The following is a description of a gene set: species: Mus musculus Any process involved in the maintenance of an internal steady state of calcium ions within an organism or cell. Mouse Gene Set: GOBP_CALCIUM_ION_HOMEOSTASIS, and this is the list of marker genes: Smdt1, Gp1bb, Fam20a, Sgcd, Cxcl11, Prkcb, Hexb, Fkbp1a, Cx3cl1, Hcrtr1, Letm1, Ccl21a, Fam3a, Ptpn6, Ccl19-ps3, Plce1, Sv2b, Trpc4, Trpv4, Synpo, Slc8a2, Slc24a5, Htr2b, Cacna1s, Myo5a, Tmbim6, Mfn2, Dhrs7c, Trpc7, Myh7b, Casr, Bdkrb1, Pdpk1, Hap1, Drd4, Drd3, Stc1, Trpc6, Trpc3, Selenok, Trpv6, Itpr1, Tmem64, Plcd1, Tmem203, Fto, Cav2, Mcub, Tmco1, Trpm2, Slc24a1, Adora1, Slc10a7, Glp1r, Lhcgr, Erc1, Bax, Htr2c, Fgfr1, Anxa7, Cxcr3 (NCBI Gene Id 12766), Atp2c2 (NCBI Gene Id 69047), Calb2, Prkca, Rgn, Ccl19-ps4, Dbi, Sppl2c, Ccl21b, Csrp3, Nt5e, Hoxa3, Atp13a2, Ccl21f, 1600014C10Rik, Gpr39, Slc24a4 (solute carrier family 24 (sodium/potassium/calcium exchanger), member 4), Stim1, Ptk2b, Ddit3, Grin1, Grin2b, Xk, Clcc1, Ryr2, Atp2b2 (NCBI Gene Id 22426), Snca, Ccr2, Calm3, P2ry2, Plcb2, Flna, Cyp27b1, Selenon, Fgf23, Kdr, Gp1ba, Cd19, Hcrtr2, Kel, Chga, Akap6, Xcr1, Atp13a4, Abcc6, Calb1, P2rx2, Erc2, Cav1, Nucb2, Ccdc47, Ccl19-ps6, Tnni3, Cib3, Gper1, Ccr1, Rmdn3, Slc37a4, Mcu, Gpr12, Pygm, Tspoap1, F2, Cyba, Edn1, Trpv5, Atp2c1, Marcksl1 (NCBI Gene Id 17357), Spp1, Cav3, Stc2, Fxn, Herpud1, Ibtk, Ank2, Npy, Ccl19-ps5, Tmtc4, Apoe, Htr2a, Grm1 (NCBI Gene Id 74875), Sri, Fxyd1, Bak1, Trpc2, Ank, Afg3l2, Calm2, Ryr1, Pik3cb, Adcy8, Npsr1, Casq2, Atp2b4, Thy1, Ccr1l1, Atp2a2, Jsrp1, Grik2, Itgav, Tmem38a, Cst5, Cemip, P2rx7, Ryr3, Atf4, Diaph1, Jph3, Fgf2 (fibroblast growth factor 2), Frey1, Tpcn2, Lcn6 (lipocalin 6), Ncs1, Enpp1, Edn2, Ccl2 (C-C motif chemokine ligand 2), Eif3e, Cacnb4, Atp2a3, Stim2, Htr1b, Ccl21d, Nol3, Calm1, Dmtn, Tcirg1, Prkd1, Ccr5, Fasl, Calcb, Slc25a23, Cacna1f, Alpl, Plcl1, Xcl1, Tunar, Plcg2, Disc1, Slc25a27, Wfs1, Sv2a, Mcur1, Gp9, Cacnb2, Vps54, Plcb3, Tnfsf11, Lyn, Cacna1a, Fgfr3, Cacna1c, Ywhae, Wnt5a, Drd2, Pdzd8, Ednra, Rap1gds1, Pthlh, Cul5, Atp2b1, Tgfb2, Cherp, Cdh23, Hrc, Plch2, Ngf, Ms4a2, Inpp4b, Itpr3, Cnr1, Atp6v1b1, Micu1, Tmem178, Ccl5, Coro1a, Vapb, Atp7b, Itpr2, Pkhd1, Vdr, Micu2, Asph (aspartate-beta-hydroxylase), P2ry1, Capn3, Tgm2, Npy1r, Fzd9, F2rl3, Tmtc2, Ccl8, Wnk4, Trim24, Maip1, Tgfb1, Snx10, Plcb4, Pkd2, Clstn1, Lck, Slc8a3, Gpr3, Slc35g1, Mtln, Atp13a3, P2rx1, Grina, Ntsr1 (NCBI Gene Id 18216), Trpm8, Slc24a2, Ghitm, Rimbp2, Il13, Thada, Slc24a3, Drd1, Grid2ip, Fcrl5, Atp1b1, Edn3, Atp13a5, Trpc5, Pacs2, Cib2, Atg5, Calca, Dmd, Slc30a1 (solute carrier family 30 (zinc transporter), member 1), Ccl21e (NCBI Gene Id 100504239), Kl, Chd7, Fkbp1b, P2ry4, Micu3, Tex101, Gstm7, Nptn, Bnip3, Pln, Osbpl2, Itgb3, Aplnr, Gp5, Ccl19-ps1, Letmd1, Cln3, Gcm2, Cdk5, Cacna1d, Atp2b3, Efhc1, Pth, Abl1, Anxa6, Slc34a1, Psen2, Htt, F2r, Psen1, Bok, Znhit1, Mettl21c, Ccl19, Gsto1, Prkce, Ctrc, Cngb1, Ptprc, Ubash3b, Cnga1, Trdn, Bcl2, Pde4d, Fate1, Tmem165, Plch1, Sypl2, Kctd17 (potassium channel tetramerisation domain containing 17), Dmpk, Clec4b1, Pth1r, Atp2a1, Slc8b1, Cxcl10, Jph2, Immt, Lime1, Atp13a1, Ccl3, Pml, Trpa1, Casq1, Slc8a1 (solute carrier family 8 (sodium/calcium exchanger), member 1), Mcoln1, Trpc1, Cd40, Camk2d, Plcg1, Cdh5, Ero1a, Kcnh1, Umod, P2ry6, Nppc, S100b, Cxcl9, Tmem38b, Plcl2, Stoml2, Plcb1, App